The following is a description of a gene set: studied in species Homo sapiens Any process that modulates the frequency, rate or extent of barbed-end actin filament capping. Human Gene Set: GOBP_REGULATION_OF_BARBED_END_ACTIN_FILAMENT_CAPPING, and this is the list of marker genes: MTPN, ASB2, WASHC2C, CRACD, CARMIL1 (capping protein regulator and myosin 1 linker 1), CARMIL2, CFL1